Given this list of marker genes Grn, Fkbp1b, Nrg1, Flna, Stk24, Pum2, Igf1r (NCBI Gene Id 77773), Ntrk3, Ndel1, Scarf1, Ptn, Hgf, Lrp1, Cntf, Braf, here is a description of the gene set: studied in species Mus musculus Any process that activates or increases the frequency, rate or extent of neuron projection regeneration, the regrowth of neuronal processes such as axons or dendrites following their loss or damage. Mouse Gene Set: GOBP_POSITIVE_REGULATION_OF_NEURON_PROJECTION_REGENERATION